Given this list of marker genes Pdgfa, Ifng, Serpinb7, Pdgfb, C3ar1 (complement component 3a receptor 1), Cflar, Bmp4, Wt1, Myc, Flcn, Itgb3, Bmp7, Il6ra, Egr1, Gata3, Lin28a, Pdgfd, here is a description of the gene set: species: Mus musculus Mouse Gene Set: GOBP_REGULATION_OF_CELL_PROLIFERATION_INVOLVED_IN_KIDNEY_DEVELOPMENT Any process that modulates the frequency, rate or extent of cell proliferation involved in kidney development.